Given this list of marker genes SLC15A3, CTNS, SLC15A4, SLC15A1, here is a description of the gene set: Reactome Pathway: SLC-mediated transport of oligopeptides studied in species Homo sapiens part of: SLC-mediated transmembrane transport This pathway serves as collection of reactions categorized as SLC-mediated transport of oligopeptides